The following is a description of a gene set: Short hard palate Human Gene Set: HP_SHORT_HARD_PALATE species: Homo sapiens Distance between the labial point of the incisive papilla to the midline junction of the hard and soft palate more than 2 SD below the mean (objective) or apparently decreased length of the hard palate (subjective)., and this is the list of marker genes: GLI2, WNT5A, DVL1, BMP4, SNRPB